The following is a description of a gene set: studied in species Mus musculus Mouse Gene Set: GOBP_REGULATION_OF_GLUCOCORTICOID_METABOLIC_PROCESS Any process that modulates the frequency, rate or extent of the chemical reactions and pathways involving glucocorticoids., and this is the list of marker genes: Atp1a1 (NCBI Gene Id 229653), Dkk3, Nr5a2, Gal, Bmp5, Rest, Bmp2, Dgkq, Stub1, H6pd, Wnt4, Nr3c1